Given this list of marker genes INSM1, RHEB, GSK3A, GSK3B, BMP6, CDK6, BAD, DLL1, CLOCK, AKT1, CDH2, SIDT2, BMAL1, PDPK1, WNT5A, NKX6-1, RFX3, GDF11, MIR541, BHLHA15, NKX2-2, BMP5, SMO, BMP4, here is a description of the gene set: The process whose specific outcome is the progression of a type B pancreatic cell over time, from its formation to the mature structure. A type B pancreatic cell is a cell located towards center of the islets of Langerhans that secretes insulin. Human Gene Set: GOBP_TYPE_B_PANCREATIC_CELL_DEVELOPMENT studied in species Homo sapiens